The following is a description of a gene set: studied in species Homo sapiens Human Gene Set: GOBP_REGULATION_OF_CELL_SUBSTRATE_JUNCTION_ORGANIZATION Any process that modulates the frequency, rate or extent of cell-substrate junction organization., and this is the list of marker genes: VEGFA, THBS1, ABL1, TLN1, PTEN, TSC1, WDPCP, SLC9A1, MAP4K4 (NCBI Gene Id 9448), SFRP1, PTPRA, DUSP3, HRG, ROCK2, PIK3R1, THY1, RAC1, EPHA3, RHOD, RCC2, MACF1, ARHGAP6, GREM1, LAMTOR2, RHOA (ras homolog family member A), POLDIP2, VCL, LDB1 (NCBI Gene Id 8861), ROCK1, DUSP22, SMAD3, MYOC, DAPK3, APOD, TEK, SRC, PPM1F, PHLDB2, EFNA5, ACTG1, GPM6B, FERMT2, COL16A1, S100A10, NRP1, CFL1, PEAK1, MAPRE2 (NCBI Gene Id 51683), SLK, ARF6 (ADP ribosylation factor 6), CAMSAP3, PTPRJ (NCBI Gene Id 5795), DLC1, SDC4, IQSEC1, KDR, DMTN, PTK2, WNT4, LIMCH1, FAM107A, MMP14, EPB41L5, CLASP1, LIMS1, CORO1C, ACVRL1, CLASP2, ITGB1BP1